Given this list of marker genes PSMC6, UBA52, PSMB4, PSMC5, PSMD2, PSMA1, PSMD11, PSMC2, PSMD3, PSMD1, PSMC1, PSMD8, PSMB6, HSPB1, PSMB2, PSMA2, PSMD14, PSMA3, PSMD12, PSMD13, PSMD6, RPS27A, UBB, SEM1, PSMB1, PSMA6, HSPA1A, HSPA8, PSMC4, PSMA7 (proteasome 20S subunit alpha 7), PSMB5, PSMA4, PSMC3, EIF4G1, PSMD7, HNRNPD, ADRM1, PSMB3, PSMB7, PSMA5, PABPC1, UBC, here is a description of the gene set: Reactome Pathway: AUF1 (hnRNP D0) binds and destabilizes mRNA part of: Regulation of mRNA stability by proteins that bind AU-rich elements studied in species Homo sapiens AUF1 (hnRNP D0) dimers bind U-rich regions of AU-rich elements (AREs) in the 3' untranslated regions of mRNAs. The binding causes AUF1 dimers to assemble into higher order tetrameric complexes. Diphosphorylated AUF1 bound to RNA recruits additional proteins, including eIF4G, polyA-binding protein, Hsp, Hsc70, Hsp27, NSEP-1, NSAP-1, and IMP-2 which target the mRNA and AUF1 for degradation. Unphosphorylated AUF1 is thought to be less able to recruit additional proteins. AUF1 also interacts directly or indirectly with HuR and the RNA-induced silencing complex (RISC).<br>AUF1 complexed with RNA and other proteins is ubiquitinated and targeted for destruction by the proteasome while the bound mRNA is degraded. Inhibition of ubiquitin addition to AUF1 blocks mRNA degradation. The mechanism by which ubiquitin-dependent proteolysis is coupled to mRNA degradation is unknown.<br>At least 4 isoforms of AUF1 exist: p45 (45 kDa) contains all exons, p42 lacks exon 2, p40 lacks exon 7, and p37 lacks exons 2 and 7. The presence of exon 7 in p42 and p45 seems to block ubiquitination while the absence of exon 7 (p37 and p40) targets AUF1 for ubiquitination and destabilizes bound RNAs. Lack of exon 2 (p37 and p42) is associated with higher affinity for RNA and 14-3-3sigma (SFN).<br>AUF1 binds and destabilizes mRNAs encoding Interleukin-1 beta (IL1B), Tumor Necrosis Factor alpha (TNFA), Cyclin-dependent kinase inhibitor 1 (CDNK1A, p21), Cyclin-D1 (CCND1), Granulocyte-macrophage colony stimulating factor (GM-CSF, CSF2), inducible Nitric oxide synthase (iNOS, NOS2), Proto-oncogene cFos (FOS), Myc proto-oncogene (MYC), Apoptosis regulator Bcl-2 (BCL2).